Given this list of marker genes CASP9, BAK1, BCL2, FADD, CFLAR, PRF1, CASP3, FASLG, CASP7, AIFM1, ENDOG, CYCS, BAX (NCBI Gene Id 581), FAS, CASP8, CASP6, HTRA2, BID, DIABLO, APAF1, here is a description of the gene set: Human Gene Set: WP_NANOMATERIAL_INDUCED_APOPTOSIS studied in species Homo sapiens Nanomaterial induced apoptosis